The following is a description of a gene set: The series of molecular signals mediated by a steroid hormone binding to a receptor. Mouse Gene Set: GOBP_STEROID_HORMONE_RECEPTOR_SIGNALING_PATHWAY studied in species Mus musculus, and this is the list of marker genes: Calcoco1, Ube3a, Or51e2, Cry2, Nr3c1, Foxp1 (NCBI Gene Id 73231), Esrrg, Cnot2, Rxra, Hmga2, Ntrk2, Nr0b1, Kdm3a, Ncoa2, Fkbp4, Zfp366, Crebrf, Nodal, Cnot1, Rnf14, Usp26, Pagr1a, Ufl1, Taf7, Ncoa3, Rhoa, Ar, Bmal1, Pak1, Shq1, Ncor1, Errfi1, Sirt1, Abhd2, Pias2, Igf1, Cnot3, Kdm5d, Ddx5, Ppara, Esr1, Esrra, Zdhhc7, Src, Pou4f2, Lmo3, Strn3, Vps11, Heyl, Trerf1, Trim68, Rwdd1 (NCBI Gene Id 74099), Prmt2, Smarca4, Ncoa1, Ufm1, Safb2, Mapk1, Kank2, Tcf21, Pgr, Scgb2a2, Carm1, Ghrhr, Hdac1, Park7, Arid1a, Gh, Foxa1, Nkx3-1, Phb2, Cyp7b1, Srarp, Esr2, Gper1, Safb, Lbh, Zbtb7a, Ufsp2, Ptges3, Cst11, Pten, Fshr, Cry1 (cryptochrome circadian regulator 1), Foxh1, Akap13, Brca1, Ppp5c, Uba5, Calr (calreticulin), Ncor2, Ddrgk1 (DDRGK domain containing 1), Jak2 (NCBI Gene Id 98155), Kmt2d, Daxx, Trp63, Parp1, Cnot9, Vps18, Bdnf, Tmf1, Sfrp1, Trip4 (NCBI Gene Id 75366), Isl1, Dnaaf4, Ep300, Rxrg, Phb1, Nr3c2, Rxrb, Lats1, Wbp2, Nedd4, Zmiz1 (zinc finger, MIZ-type containing 1), Med1, Kdm4c, Ppargc1b, Clock, Rbfox2, Dnaja1 (NCBI Gene Id 18001), Dab2, Ywhah, Klf9, Padi2, Ubr5, Ddx17, Pde3a (NCBI Gene Id 97334), Esrrb, Skp2, Per1, Rnf6